Given this list of marker genes SLC10A7, ZDHHC17, CYP39A1, ZMYND11, NEUROD4, ZNF441, CD1E, ZFP36L2, DRD1, RALGAPA1, ADGRL2, FYTTD1, PLPP5, PARP9, VAT1L, BAG2, MINDY3, HTR2C, ANKRD29, GSPT1, PTCHD4, ARHGEF18, INTS8, KBTBD2, YWHAQ, THUMPD1, GPBP1, TCTN3, OXTR, ACOT13, SLU7, TMEM182, MZT1, NXT2, GOLGA1, ULBP3, HECW2, RAD51B, KRAS, CHL1, KLF3, PPARGC1B, VAPA, NR2E1, SEC24A, ECT2, PCGF6, DHODH, MTERF2, UBR5, HNRNPA0, NANOS1, SECISBP2L, ANXA5, CLCN4, here is a description of the gene set: Human Gene Set: MIR449C_3P from publication Chen Y, Wang X (PMID 31504780) Genes predicted to be targets of miRBase v22 microRNA hsa-miR-449c-3p in miRDB v6.0 with MirTarget v4 prediction scores > 80 (high confidence targets). studied in species Homo sapiens